The following is a description of a gene set: Human Gene Set: UNTERMAN_IPF_VS_CTRL_B_CELL_DN species: Homo sapiens Genes downregulated in B cells from Idiopathic Pulmonary Fibrosis Patients vs. Controls Thirty-eight PBMC samples from 25 patients with IPF and 13 matched controls yielded 149,564 cells that segregated into 23 subpopulations. Classical monocytes were increased in progressive and stable IPF compared to controls (32.1%, 25.2%, 17.9%, respectively, p<0.05). Total lymphocytes were decreased in IPF vs controls, and in progressive vs stable IPF (52.6% vs 62.6%, p=0.035). Tregs were increased in progressive vs stable IPF (1.8% vs 1.1% of all PBMC, p=0.007), although not different than controls, and may be associated with decreased survival (P=0.009 in Kaplan-Meier analysis; P=0.069 after adjusting for age, sex, and baseline FVC). Flow cytometry analysis confirmed this finding in an independent cohort of IPF patients. Fraction of Tregs out of all T cells was also increased in two cohorts of lung scRNA-seq. CCL22 and CCL18, ligands for CCR4 and CCR8 Treg chemotaxis receptors, were increased in IPF. The single-cell atlas of the peripheral immune system in IPF, reveals an outcome-predictive increase in classical monocytes and Tregs, as well as evidence for a lung-blood immune recruitment axis involving CCL7 (for classical monocytes) and CCL18/CCL22 (for Tregs). (From Abstract) from publication Unterman A, Zhao AY, Neumark N, Schupp JC, Ahangari F, Cosme C Jr, Sharma P, Flint J, Stein Y, Ryu C, Ishikawa G, Sumida TS, Gomez JL, Herazo-Maya JD, Dela Cruz CS, Herzog EL, Kaminski N (PMID 38717443), and this is the list of marker genes: KLF6, IGLC2, RHOH, ZFP36, H3-3B, FOS, IGLC3, EGR1, ZNF331, RGS2, PPP1R15A, H1-4, GPR183, CD83, YPEL5, IER2, DUSP1, BTG2, TENT5C, NR4A1, NR4A2, PELI1, EIF1, PDE4B, CD69, IFITM3, HERPUD1, CXCR4, DUSP2, TSC22D3, SAT1, RHOB, JUNB, AREG, JUN, SBDS